The following is a description of a gene set: The p53 tumour suppressor functions as a transcriptional activator, and several p53-inducible genes that play a critical proapoptotic role have been described. Moreover, p53 regulates the expression of various proteins participating in autoregulatory feedback loops, including proteins that negatively control p53 stability (Mdm2 and Pirh2) or modulate stress-induced phosphorylation of p53 on Ser-46 (p53DINP1 or Wip1), a key event for p53-induced apoptosis. Here, we describe a new systematic analysis of p53 targets using oligonucleotide chips, and report the identification of dapk1 as a novel p53 target. We demonstrate that dapk1 mRNA levels increase in a p53-dependent manner in various cellular settings. Both human and mouse dapk1 genomic loci contain DNA sequences that bind p53 in vitro and in vivo. Since dapk1 encodes a serine/threonine kinase previously shown to suppress oncogene-induced transformation by activating a p19ARF/p53-dependent apoptotic checkpoint, our results suggest that Dapk1 participates in a new positive feedback loop controlling p53 activation and apoptosis. from publication Martoriati A, Doumont G, Alcalay M, Bellefroid E, Pelicci PG, Marine JC (PMID 15608685) Mouse Gene Set: MARTORIATI_MDM4_TARGETS_FETAL_LIVER_DN Genes down-regulated in non-apoptotic tissues (fetal liver) after MDM4 knockout. studied in species Mus musculus, and this is the list of marker genes: Erbin, Alas2, Safb2, Cbx5 (chromobox 5), Gng2, Lrrc58, Slc39a10, Pik3r1, Epha4, Rbp4, Pja2, Sfswap, Rcc2, S1pr3, Ddx17, Sec23a, Qki, Ppm1b, Csnk1d, Cnot7, Odf2, Agap3, Dgcr8, Efhd2, Tcf4, Postn, Cttn, Csf2rb, Nnat, Prkci, Plxna2, Col9a1, Clic1, Celf1, Slc44a1, Timp2 (NCBI Gene Id 52894), Ankrd28, Tcf21, Spin1, Eprs1, Nr2f1, Ilrun, Xiap, Arl8b, Hnrnph3, Pten, Lpl, Usp19, Gli3, Foxf1, Tnpo3, Slc13a4, Fzd5, St3gal5, Fbxw8, Fbxw11, Mllt10, Ago2, Atic, Eif4g1, Pogk, Epb41l3 (NCBI Gene Id 56528), Gulo (NCBI Gene Id 30047), Otud4, Kin, Faf1, Smad3 (NCBI Gene Id 17127), Dusp18, Lpar1, Mapkapk2, Msl1, D17H6S56E-5, Dbt, Arid4b, Thap11, Cited4, Ensa, Atrx, Dpf3, Arb2a, Fyttd1, Rab10, Efna5, Atxn2, Pcyt1a, Shroom3, Alcam, Itih2, Satb1, Nhlh2, Ssr1, Foxm1 (forkhead box M1), Casp9, Zfp422, Ykt6, Enah, Pphln1, Cop1, Acbd4, Gtf3c2, Gata4, Smc6, Cad, Ddx21, Prkar2a, Atf7ip, Exoc5, Flrt3, Igfbp1, Bclaf1, Kif1b, Edem1, Magt1, Rnf20, Men1, Zfpm1, Dcn, Usp48, Pola1, Hus1, Zfand5, Plvap, Trak2, Ermap, Prpf6, Norad, Papola, Sec63, Actr1b, Serpina1b, Ppig, Polr3c, Cnot11, Baz1b, Rcbtb2, Apom, Prc1, Marchf7, Fermt2, Epha3, Snw1, Cbx2, Tmem248, Abcf1, Nck2, Stk3, Thrap3, Abcg2, Reln, Pcbp4, Acp1, Prrx1, Adam10, Twsg1, Stard4, Atp11c, Arf3, Ttr, Stambp, Bcl11a, Slc16a13, Angpt1, Angptl2, Add3, Lasp1, Ddx18, Dpysl3, Cnot6l, Gpc2, Pmpca, Col1a2, Anapc5, Col5a2, Tbkbp1, Fga, Foxp1, Pheta1, Cubn, Zfp260, Tshz1, Tent5c, Epb41l2, Srsf1, Csnk1g3, Med16 (mediator complex subunit 16), Slc2a2, Apoa4, Efnb3, Fubp1, Dact3, Ghr, Isg20l2, Fads2, Zfp146, Hp1bp3, Trap1a, Brd8, Cage1 (cancer antigen 1), Tfrc, Akap10, Tpm4, Btbd2, Hipk3, Rbm5, Lmo4, Nono, Scarf2, Hand2, Tpr, Tcf7l2, Pank3, Clip3, Cd1d1, Ccar1, Sec24b, Gata6, Sgpl1, Ppfia1, Mapre1, Maco1, Fgb, Epm2aip1, Kat2b, Ncl, Pdgfra (NCBI Gene Id 231312), Hacd3 (3-hydroxyacyl-CoA dehydratase 3), Lcp1, Rbm25, Maob, Dhx9, Gucy1a1, Lypla1, Rfk (NCBI Gene Id 67438), Bdnf, Ppp6r1, Kpna3, Dnajc7, Ubqln4, Slc25a13, Sh3glb1, Tbl3, Srpra, Slc31a2, Lemd3, Clcn5, Ckap4, Zfp36l2, Amd-ps1, Fgg, Vcl, Pole3, Cept1, St13, Mbnl2, Serpinf2, Agps, Rps6kb1, Mtdh, Ubap2, Spart, Capn6, Cyth3, Sp4, Rbbp9, Snx2, Nfatc3, Fem1b, Nemf, Tbrg4, Mia3, Csf1r, Mark2, Cert1, Arpc1b (NCBI Gene Id 50737), Plagl1, Nucks1, Utp15, Vcam1, Cwf19l1, Mettl16, D1Pas1, Myb, Zfp574, mt-Cytb, Ro60, Lhx9, Smc1a, Sphkap, Selenoi, Rbfox2, Mknk2, Irf2bpl, Ssr3, Asb4, Apoe, Ets1, Ing3, Ufd1 (ubiquitin recognition factor in ER-associated degradation 1), F2r, Ubl7, Dact1, Pafah1b2 (platelet-activating factor acetylhydrolase, isoform 1b, subunit 2), Grb10, Tbx3, Apob, Hcfc1 (host cell factor C1), Gps2, Rsrc2, Pnisr, Map1b, Kif11, Bub1, Nolc1, Slc4a1 (solute carrier family 4 (anion exchanger), member 1), Tmem64, Gramd2b, Peli1, Phf20l1, Abcb7, Snx1, Glyr1, Amn, Slc25a46, Plg, Mtmr4, Ctdsp2, Mdm4, Stau1, Scyl2, Nudt4, Tbx2, Mef2a, Shox2, Atxn7l3b, Ccnt2, Cdh2, Arnt, Zfp26, Cdc27, Alg2, Mmp14, Il6st, Ubxn4, Rangap1, Trp53-ps, Pitpnb, Pbx3, Rcbtb1, Cttnbp2nl, Ovca2, Kctd20, Matr3, Bnc1, Abcf2, Pctp, Car7, Spag5, Pln, Basp1, Gpbp1, Ccser2, Gna12, Sfpq, Atp2b1, Atp8a1, Fam32a, Gnai3, Aco1, Bag6, Arhgap5, Ivns1abp, Pdia6, Rnf2, Kif15, Cbl, Mab21l2, Zfp830, Dhx29, Tgfbr1, Pard6b, Sh3d19, Rbm28, Mtus2, Incenp, Lix1l, Olfm1, Tmem33, Upk3b, Gtf2f1, Naa50, Chp1, Pdzk1, Lrrc59, Slc39a8, Adprs, Rtf1, Fzd1, Wnt5a, Tll1, Pim1, Zmynd11, Cntrl, Ugcg, Smarca5, Nup205, Pofut2, Sec62, Slc38a2, Wdr26, Col1a1, Usp16, Slc12a7, Tnfaip1, Ufm1, Pitx2, Anp32e (NCBI Gene Id 99603), Wbp1l, Fkrp, Amd1, Ptprg, Cox15, Zkscan1, Tmprss2, Mecom, Cilk1, Actr2, Sh3bp5, Sgo2a, Hemgn, Hdlbp, Igdcc3, Ogfrl1, Utrn, Suz12, Eif5b, Kank2, Ythdf3, Hmox1 (NCBI Gene Id 27970), Dtl, Rmnd5a, Pgm5, Rnf38, Cand1, Fam168b, Prpf40a, Dgcr2, Rhox5, Ppp4r1, Pramel12, Ganab, Clpx, Plpp3, Nras, Lin7c, Mapk1ip1l, Rock2, Hnrnpa1, Hmg20b, Tbc1d2b, Psap (NCBI Gene Id 19156), Zfp148, Usp22, Supt16, Rwdd4a, Ell2, Srek1, Ssbp4, Sox4, Nfyc, Snx5, Nrk, Zbtb12, Rcor3, Ctsc, Tbl1x, Apoa1, Rhag, Alb, Rab22a, Tmx4, Shc1, Klf3, Rab7, Cstf3, Hsd11b2, Prpf38b, Zfp143, Maf, Prkar2b, Ak3, Tgif2, Utp3, Nufip2, Tnc, Umps, Mbd1, Ap1g1, Zcchc14, Plxnb2, Fgfr2, Gm8113, Tirap, Ywhag, Trpc4ap, Nab1, Rnf220, Hmgcr, Zfa-ps, Ambp, Serpina1a, Septin1, Skic2, Acp5, Mllt1, Lpp, Zfp106, Knop1 (lysine rich nucleolar protein 1), Tgoln1, Cul3, Prpf19, Son, Car2, Tbx15, Pknox1, Tia1